Given this list of marker genes RPL35, SERBP1, EIF4B, CHST10, TUBB, RPL19, DCUN1D5, NDUFB6 (NADH:ubiquinone oxidoreductase subunit B6), PCNA, CDC123, EIF4A1, NUDT21, RPL22L1, RPS6 (NCBI Gene Id 92956), ATP5MG, RPLP2, CD247, RPS3A, RBBP4, RPS15A, ACTB, RPL17, RPL37, TBCA, TMA7, RPS19, TRAF4, TPT1, RPL24, CNP, HINT1, CKS2, RPS5, LAPTM5, RGCC, HADHA, RPS16, SDHD, PPP2R5A, RPL13A, SLC6A19, STMN1, SLC25A6, EIF3I, RPL23, TUBA1B, NUCKS1, TRAPPC3 (trafficking protein particle complex subunit 3), HNRNPU, RPS14, ARL6IP1, RPL14, RRM2, ARF1, TXN, PPIA, MCM7, PSMC3, RPS4X, UBXN8, C1QBP, CWC15, COX6B1, RFC3, PPP1CC, IGHM, CNBP, CCT5, COX5A, RPS8, DAZAP2, UBE2L3, CHTOP, EEF1G, RPS29, NUDT3, PSMA6, DDX5, PCLAF, RPL7A, AKR1A1, HMGB1, H2AZ1, RPL27A, ETS1, SRSF2, NUTF2, RPL9, RPA3, CTSV, RPLP0, LCK (LCK proto-oncogene, Src family tyrosine kinase, NCBI Gene Id 95387), EIF3H, RPS3, CAPZB, HNRNPC, OAZ1, RPL31, RPL3, CHCHD2, ATP5PB, RPL22, RPS18 (NCBI Gene Id 6222), FABP5, GDI2, NFATC3, PRKAR1A, RPL28, RPL27, MRFAP1L1 (Morf4 family associated protein 1 like 1), PABPN1, SKIC2, DNTT, MIDN, ACTG1, RAN (RAN, member RAS oncogene family), UQCRB, ANXA2 (annexin A2), RBMXL1 (NCBI Gene Id 494115), RPSA, RPL6, ARPC3, NDUFA1, PSMA1, MRPL30, CYB5A, RPL18, SMARCC2, RPL36 (ribosomal protein L36), RPL38, PAM16, RPL11, RPS9 (ribosomal protein S9), RPS7, DYNLT1, PRDX1, RAP1B, RAB2A, KPNA2, ATP5PO, RPS11, LIMD2, RPS25, HSP90AA1, PTP4A2, ATP5MC3, SNRPG, CDK2AP1, HSPA8, RPS21, RPL18A, RPS23, CSNK2B, RPL5, ATP6V1G1, RPL37A, LDHB, ARPC2, YBX1, SMARCD2, EEF1B2, HNRNPAB, RPL4, EIF4G2, RPS10, UBE2D3, ZSCAN2, MKI67, SRSF3, RPL30, ACTR3, ATP5F1C, RPL39, NPM1, RPS27L (ribosomal protein S27 like), COX6A1, RBM38, SELENOW, KXD1, RPL34, RPS2, RPL26, RPL7, RPL23A, TPM3, VCP, CD3G, LDHA, RPS27, SELENOP, RACK1, RPS26, B2M, PSME1, YWHAZ, TKT, RPL12, RPL13, CXCL12, RPL10, here is a description of the gene set: Genes down-regulated in polymorphonuclear leukocytes (9h): control versus infection by A. phagocytophilum. studied in species Homo sapiens Polymorphonuclear leukocytes (PMNs) were obtained from healthy individuals in accordance with protocols approved by the Institutional Review Board for Human Subjects at the University of Minnesota and the National Institute of Allergy and Infectious Diseases. PMNs (107) were combined on ice with live S. aureus (108) or with live or heat-killed A. phagocytophilum (bacteria isolated from 5x106 infected HL60 cells for a ratio of 1 infected HL60 cell: 2 PMNs, ~ 5-20 A. phagocytophilum: PMN) in wells of a 12-well tissue culture plate (pre-coated with 20% autologous normal human serum). Unstimulated control assays received either buffer (for S. aureus comparisons) or clarified HL60 lysate (for A. phagocytophilum comparisons). Plates were centrifuged at 350 x g for 8 min at 4oC to synchronize phagocytosis and incubated at 37 deg. C in a CO2 incubator for the indicated times. At the indicated times, tissue culture medium was aspirated from the plate and PMNs were lysed directly with RLT buffer (Qiagen, Valencia, CA). Purification of PMN RNA and subsequent preparation of labeled cRNA target was performed as described in Methods. Labeling of samples, hybridization of cRNA with HU133A oligonucleotide arrays (Affymetrix, Santa Clara, CA), and scanning were performed according to standard Affymetrix protocols ( http://www.affymetrix.com/pdf/expression_manual.pdf ). Experiments were performed in triplicate, using PMNs from three healthy individuals for each treatment. from publication Borjesson DL, Kobayashi SD, Whitney AR, Voyich JM, Argue CM, Deleo FR (PMID 15879137) Human Gene Set: GSE2405_0H_VS_9H_A_PHAGOCYTOPHILUM_STIM_NEUTROPHIL_DN